The following is a description of a gene set: species: Homo sapiens Human Gene Set: HSIAO_LIVER_SPECIFIC_GENES from publication Hsiao LL, Dangond F, Yoshida T, Hong R, Jensen RV, Misra J, Dillon W, Lee KF, Clark KE, Haverty P, Weng Z, Mutter GL, Frosch MP, MacDonald ME, Milford EL, Crum CP, Bueno R, Pratt RE, Mahadevappa M, Warrington JA, Stephanopoulos G, Stephanopoulos G, Gullans SR (PMID 11773596) Liver selective genes This study creates a compendium of gene expression in normal human tissues suitable as a reference for defining basic organ systems biology. Using oligonucleotide microarrays, we analyze 59 samples representing 19 distinct tissue types. Of approximately genes analyzed, genes are expressed in all tissue types and designated as housekeeping genes. These genes display significant variation in expression levels among tissues and are sufficient for discerning tissue-specific expression signatures, indicative of fundamental differences in biochemical processes. In addition, subsets of tissue-selective genes are identified that define key biological processes characterizing each organ. This compendium highlights similarities and differences among organ systems and different individuals and also provides a publicly available resource (Human Gene Expression Index, the HuGE Index, http://www.hugeindex.org) for future studies of pathophysiology., and this is the list of marker genes: FMO5, MGST1, PCCB, SERPINF1, APOB, GYS2, SULT2A1, PLIN2, MGST2, AFM, ACOX2, TST, CASC3, CYP4F2, SAA4, APOA1, KNG1, ACADSB, F12, FAH, ACAA2, BZW1, CYP2B6, CFI, ADH1B, FGA, PCK2, RGL2, SC5D, ACAT1, FST, HSD17B4, PROS1, NR1H4, ACSM3, LPA, CPN2, RIDA, NR0B2, HRG, LIPC, AHSG, HNMT, PCSK6, GPT, PON3, CRP, SERPINE1, CYP2J2, APOC1, HGD, F10, CYP2E1, NAT2 (N-acetyltransferase 2), SERPINF2, CBS, SERPINA5, C8B, IGFBP1, GATM, DHCR24, CYP2D6, ATP13A3, CYP3A4, SERPINA1, ALDH2 (aldehyde dehydrogenase 2 family member), GJB1, KYNU, RARRES2, IL13, CES2, AZGP1, SSRP1, MBL2, F9, HGFAC, CPB2, SERPINA7, APOF, SLC39A14, ABCB4, NNMT, PGRMC1, CES1, APOC3, SLC2A2, PCBD1, SPP2, CPS1, CAT, ORM1, SERPINC1, ALDOB, UGT2B7, PLG, ALB, SLC10A1, CDO1, CFHR4, PYGL, ITIH1, ABCC2, SERPIND1, MTTP, BAAT (NCBI Gene Id 570), GSTZ1, LAMP2, MST1, FGL1, LCAT, LPIN2, APOA2, ASS1, RBM4, ASGR2, SERPINA3, NAMPT (NCBI Gene Id 10135), UGT2B4, RGN, SEPHS2, F13B, CYP2A6, HAL, DECR1, ACAA1, CYP4F3, UGT2B15, LSR, C4A, ASGR1 (asialoglycoprotein receptor 1), GGCX, UGT1A10, F11, PROC, CYP4A11, CYP3A7, C1S, SDS, FURIN, ID2B, F2, APOE, TF, IL13RA1, GHR, GSTA2, FGG, CRHBP, SERPING1, GCH1, CFB, GLUD1, CYP2C18, CDH2, C1R, DDT, SUPT4H1, HPD, ABCC6, HSD11B1, APOC4, TDO2, LGALS4, EPHX1, C3, MMUT, ADH6, SORD, CYB5A, F7, FABP1 (fatty acid binding protein 1), AKR1C4, ACSL1, FCN2, HABP2, TTR, AKR1D1, APOC2, SOD1, PTGR1, FBP1, PZP, HPN, ADH4, ARG1, SAA1, POR, TFPI, C4BPA, FGB, SERPINA6, ADH1A, GSTA1, ITIH2, BDH1, TAT, ALDH6A1, ITIH3, APOH, HP, CYP27A1 (cytochrome P450 family 27 subfamily A member 1), DPYS, CFH, AADAC (NCBI Gene Id 13), PRDX4, AGXT, CYP2C9, C9, CXCR2, TM4SF4, KLKB1, C5, ALAS1, F5, SHMT1, MTHFD1, AKR1C1, RBP4, AGT, GSTO1, CFHR2, TAF6, ITIH4, OTC, PCK1 (NCBI Gene Id 5105, phosphoenolpyruvate carboxykinase 1), PLOD2, BHMT, ANG, SLC38A3, HMGCL, AOX1, CRADD, HPX, C4BPB, APCS, MSMO1, NCOR2, G6PC1, C8A, ASL, SELENOP, CP, C8G, FGFR4, FMO3 (flavin containing dimethylaniline monoxygenase 3), VTN, HMGCS2, AGTR1, ALDH1A1